The following is a description of a gene set: Genes predicted to be targets of miRBase v22 microRNA hsa-miR-586 in miRDB v6.0 with MirTarget v4 prediction scores > 80 (high confidence targets). studied in species Homo sapiens from publication Chen Y, Wang X (PMID 31504780) Human Gene Set: MIR586, and this is the list of marker genes: DKK2, SORCS3, NSMAF, TOX4, PRKAA1, JAZF1, RIMBP2, FGFR1OP2, MTRF1L, UBE2W, SNRPN (NCBI Gene Id 6638), ABCA1, FAM133B, STK38, P2RY1, HECW2, AFF4, SRSF7, ZIC2, SETX, MLLT3, KCNQ5, ANO3, PCDHB7, SLC1A2, HAGH, NEUROD6, GYPA, TMEM196, SLC44A1, C1GALT1, RSF1, SH3GLB1, ATP8A1, RNGTT, KCTD6, CLU, IDO1, CCDC6, CLDN20, SHCBP1, CD2AP, ATAD2, PCDH18, TP53INP1, RBL2, ITPR1 (NCBI Gene Id 619543), SPARCL1, SEMA3A, FAM76B, MRPS16, KCNE1, SNX20, SP3, ATG4C, CNTNAP4, CTNNA1, INPP5E, PLCB1, SNX13, C6orf120, PRKAR2B, TPT1, AJAP1, SLC25A4, PCM1, SNAI2, LRRC8D, CABP7, LIPI, CTSS, PLEKHA8, FLVCR1, SLC25A5, SEC24B, MYNN, BCL11A, IGFBP5, SLC7A14, TPM3, UNC13C, CNOT11, PRKD1, PPARG, AZI2, CAPZA2, CRISPLD1, PDE12, FAM227B, SGCE, UBASH3B, PPP1CC, KIF1B, MS4A6E, TANC2 (NCBI Gene Id 80259), CYP24A1, DICER1, SHC3, DENND1B, GTPBP10, ZFR, CFLAR, STK26, SPTLC3, SLC30A5, KCNA1, COPA, BEND4, NR1D2, MGAT4B, LMBR1, ZC3H6, WTAP, IL1RAP, AFG2B, TRIP13, IQGAP1, ZNF468, MZT1, MFAP5, VWC2, GPR137C, ATL2, MRPS25, VPS35, EREG, BMI1, STRN3, NEUROD1, ZDHHC15, UBE2D2, LIN9, CTNND2, PRKCI, ZNF568 (NCBI Gene Id 654171), UBE2D3, AGBL3, KDM2B (lysine demethylase 2B), ACSL6, TSPAN1, GABRA4, GLS, BNC2, PDE10A, TFEC, SATB2, GSPT2, TLR7, SLC12A1, ZNF277, MBOAT4, ZBTB25, KLHL32, GABPA, CADM2, RANBP9, UBE2E1, RSBN1 (NCBI Gene Id 54665), TEK (NCBI Gene Id 7437), EDN3, SLC26A4, PPP4R4, SCN3A, HBS1L, SCN9A, PTPRC, WDR17, GLOD5, VCL, CPEB2, TNFSF15, ZNF154, ZNF91, ZNF148, SLF2, HSPA2, MED12L, MAGI1, GPM6A, UBE2K, BTAF1, KIFAP3, KCND2, CAMK2D, NCK1, CLDN15, TRIM33, TMEM168, MBNL1, ATP8A2, DNM1L, CLTC, RERG, KCNV1, CCDC186, THAP6, ELF2, KPNA3, PCDH9, COMMD3-BMI1, RAB2A, SFPQ, NETO1, SYDE2, CPEB4, RGS7BP, ZNF711, ARL13B, TMED7, N4BP2L2, PPP1CB, DLK1, SLC2A12, UBR1, ZNF146, TBL1XR1, USP46, LCA5, ARHGAP32, GPR26, TRMT10A, BRDT, PPP1R2 (protein phosphatase 1 regulatory inhibitor subunit 2), SNX16, ARL4C, THBD, RNF103, CARD19, GDI2, ATP5F1A, IL18R1, FMNL2 (NCBI Gene Id 114793), MPEG1, VPS13A, KHDC4, KERA, HSD17B12, GABRB3, PSMF1 (NCBI Gene Id 9491), UBR7, MTSS1, FBXW7, CPNE3, AGPS (alkylglycerone phosphate synthase), PPP3CB, SPIRE1, MTX3, CDC42BPA, CTNNA2 (catenin alpha 2), ANGPTL1, USP15, DCX, MYOCD, CTSV, DNAJB14, SEPTIN7, CSRNP3, KCNK1, FERMT2, KLHL13, ADGRL3, NEFM (neurofilament medium chain), PCDH19, SYT1, ICA1L, FBLIM1, FASLG, ACVR1, GALNT1, BNIP2, CSMD3, ZC2HC1A, TAFA2, TNPO1